The following is a description of a gene set: Any process that determines the size and arrangement of collagen fibrils within an extracellular matrix. species: Mus musculus Mouse Gene Set: GOBP_COLLAGEN_FIBRIL_ORGANIZATION, and this is the list of marker genes: Col6a1, Rb1 (NCBI Gene Id 19645), Adamts2, Adamts7, Anxa2, Ddr2, Loxl2, Vps33b, Serpinh1, Col2a1, Grem1, Cyp1b1, Loxl3, Atp7a, Col1a1, Zfp469, Emilin1, Scx, Col5a2, Foxc1, Mmp11, Vipas39, P4ha3, Ext1, Nf1, Loxl4, Pxdn, Col14a1, Acan, Fkbp10, Ero1a, Adamts12, Serpinf2, Plod1, Chadl, Col1a2, Adamts14, P3h4, Col3a1, Lmx1b, Adamts19, Mia3, Crtap, Mkx, Plod3, P3h1, Foxc2, Optc (opticin), Lox, Tgfb2, Antxr2, Comp, Sfrp2, Dpt, Plod2, Efemp2, Selenon, P4ha1, Colgalt1 (collagen beta(1-O)galactosyltransferase 1), Col5a1, Col11a2, Tgfbr1, Col11a1, Tnxb, Aebp1, Loxl1